The following is a description of a gene set: Reactome Pathway: Activation, translocation and oligomerization of BAX As a result of binding to Bid, Bax oligomerizes and integrates in the outer mitochondrial membrane, triggering cytochrome c release. Bax mitochondrial membrane insertion triggered by Bid may represent a key step in pathways leading to apoptosis. studied in species Homo sapiens part of: Intrinsic Pathway for Apoptosis, and this is the list of marker genes: BID, BAX